Given this list of marker genes Idh3b, Rnaseh1, Tssk2, Nt5c1a, Suclg2, Thtpa (thiamine triphosphatase), Idi1, Prkacb, Mark2, Pde2a, Mapk12, Pgm5, Rap2a, Map2k7, Ncs1, Papola, Pdcd6, Itgb1, Aasdhppt, Mvk, Gem, Atp10b, Adprhl1, Hacl1, Srpk1, Mast2, Atp10a, Rps6ka5, Cdc123, Nt5c3, Plscr1, Exd2, Farsb, Brsk1, Pgm2, Idi1-ps1, Kcnip3, Cdc42bpb, Pgp, Atp8a1, Wee1, Cdc42bpg, Lig4, Polr3a, Pkm, Polr1a, Hprt1, Prim1, Atp8b1, Endov, Trex2, Pink1, Pdxp, Gclc, Map3k8, Ppa1, Ppm1n, Septin4, Oxsr1, Prps1, Abl2, Thg1l, Rps6ka6, Pdxk, Snca, Itpk1, Irak4, Idh3a, Adprh, Akp3, Mthfd2, Tkt, Wee2, Tssk4, Atp10d, Rheb (Ras homolog enriched in brain), Extl3, Map3k20, P2rx7, Atp11a, Idh2, Wrn, Nudt7, Tssk5, Mark1, Cib4, Pgm1, Ern2, Wnk1, Pgm3, Ern1, Arf1, Atp9b, Adss1, Top2a, Cilk1, Adss2, Rps6ka1, Eno1, Ilk, Pdp1, Pck1, Dhx36, Map3k7, Ppm1a (NCBI Gene Id 72917), Mast3, Gss, Atp9a, Impa1, Irak3, Ilvbl, Prkaca, Prpsap2, Mast4, Tdg-ps, Dyrk2, Idh1, Mast1, Clybl, Sik2, Gck (glucokinase), Cib3, Sphk1, Snrk (NCBI Gene Id 97116), Arl3, Hpgds, Dck, Msh6 (NCBI Gene Id 17688), Nt5c1b, Endog, Tssk3, Comt, Atp8b5 (NCBI Gene Id 320571), Nudt5, Lrrk2, Tdp2, Stk38, Nlk, Ydjc, Cib1, Sik1, Rps6ka3, Tssk6, Polq, Atp4a, Gnai1, Uba2, Dxo, Plscr3, Cdc42bpa, Prps2, Nudt8, Foxk2, Plscr2, Tppp, Srpk2, Map3k5, Adcy10, Eya2, Dctpp1, Srr, Rps6ka2, Msh2, Nuak2, Hmgcl, Pif1, Ppa2, Pklr, Ran, Sik3, Atp8b2, Lats1, Idh3g, Atp8b3, Fignl1, Mtpap, Nudt12, 4933405O20Rik, Psph, Atp11b, Prpsap1, Rps6ka4, Xxylt1 (xyloside xylosyltransferase 1), Dis3l2, Abl1, Nim1k, Atp8a2, Fen1, Farsa, Cerk, Cib2, Enoph1, Csnk1a1, Tdg, Xylt2, Dut, Plk1, Glul, Adprs, Gen1, Atp11c, Bpnt1, Nudt19, Adcy2, Mat1a, Morc2b, Stk3, Stk4, Nek6, Rexo2, Me1, Tufm, Nt5c3b (NCBI Gene Id 69924), Gtpbp10, Eno4 (NCBI Gene Id 226265), Nudt3, Cdk2 (cyclin dependent kinase 2), Ppm1b, Eno2, Brsk2, Map3k6, Rp2, Tssk1, Morc2a, Tesc (NCBI Gene Id 80653), Eno3, Ephx2, Dyrk3, Stk11, Sucla2, Alpi, Polr2a, Stk38l, Nudt16, Nme1, Stk26, Trex1, here is a description of the gene set: Mouse Gene Set: GOMF_MAGNESIUM_ION_BINDING studied in species Mus musculus Binding to a magnesium (Mg) ion.